The following is a description of a gene set: species: Homo sapiens Absent or minimally ossified vertebral bodies Human Gene Set: HP_ABSENT_OR_MINIMALLY_OSSIFIED_VERTEBRAL_BODIES, and this is the list of marker genes: IFT80, DYNC2H1, ALPL, BMPER, LBR, WDR35 (WD repeat domain 35), SOX9, SLC26A2, DYNC2I1 (dynein 2 intermediate chain 1), VPS35L, COL2A1, DYNC2I2, TRIP11, FLNB